Given this list of marker genes MICOS10-NBL1, GPR18, DPP4, TNFAIP6, MIR223, KLRC4-KLRK1, GREM1, CCL2, C5, CCN3, DDT, KLRK1, NBL1, CYP19A1, RIN3, SLAMF8, MIF, MMP28, STAP1, PADI2, C5AR2, DUSP1, SLIT2, here is a description of the gene set: Any process that stops, prevents, or reduces the frequency, rate, or extent of leukocyte chemotaxis. Human Gene Set: GOBP_NEGATIVE_REGULATION_OF_LEUKOCYTE_CHEMOTAXIS species: Homo sapiens